Given this list of marker genes Cyp4a29 (NCBI Gene Id 230639), Cyp4a12a (cytochrome P450, family 4, subfamily a, polypeptide 12a), Cyp4b1, Ptgis, Cyp4f40, Cyp4a30b, Cyp4f15, Cyp8b1, Cyp4f39, Cyp4f18, Cyp4a10, Tbxas1, Cyp4a31, here is a description of the gene set: electronically inferred by orthology from the curated human pathway part of: Cytochrome P450 - arranged by substrate type studied in species Mus musculus Reactome Pathway: Eicosanoids This event has been computationally inferred from an event that has been demonstrated in another species.<p>The inference is based on the homology mapping from PANTHER. Briefly, reactions for which all involved PhysicalEntities (in input, output and catalyst) have a mapped orthologue/paralogue (for complexes at least 75% of components must have a mapping) are inferred to the other species.